Given this list of marker genes Fgf6, Gab1, Fgf20, Fgf1, Klb, Fgf8, Fgf23, Frs2, Fgf2, Fgf16, Grb2, Fgf4, Fgf15, Fgf17, here is a description of the gene set: part of: Downstream signaling of activated FGFR4 Reactome Pathway: PI-3K cascade:FGFR4 electronically inferred by orthology from the curated human pathway This event has been computationally inferred from an event that has been demonstrated in another species.<p>The inference is based on the homology mapping from PANTHER. Briefly, reactions for which all involved PhysicalEntities (in input, output and catalyst) have a mapped orthologue/paralogue (for complexes at least 75% of components must have a mapping) are inferred to the other species. species: Mus musculus